The following is a description of a gene set: Functions during translation by binding to RNA during polypeptide synthesis at the ribosome. Human Gene Set: GOMF_TRANSLATION_FACTOR_ACTIVITY_RNA_BINDING species: Homo sapiens, and this is the list of marker genes: EIF4E2, CPEB4, EIF1AX, GCN1, EEF2K, MTIF2, EIF4H, EIF2S3, EIF2B3, EIF4A1, EIF1, CPEB2, EIF4G1, EEF1D, EIF2S2, EIF4G3, MTIF3, CPEB3, EEF1A2, EIF4G2, CPEB1, ABCF1 (ATP binding cassette subfamily F member 1)